The following is a description of a gene set: Enables the transfer of manganese (Mn) ions from one side of a membrane to the other. studied in species Homo sapiens Human Gene Set: GOMF_MANGANESE_ION_TRANSMEMBRANE_TRANSPORTER_ACTIVITY, and this is the list of marker genes: ATP13A1, SLC11A1, ATP2C1, ATP2C2, SLC39A14, TRPM2, SLC30A10, SLC11A2, TMEM165 (NCBI Gene Id 55858)